The following is a description of a gene set: Human Gene Set: GOBP_POSITIVE_REGULATION_OF_PROSTAGLANDIN_BIOSYNTHETIC_PROCESS species: Homo sapiens Any process that activates or increases the frequency, rate or extent of the chemical reactions and pathways resulting in the formation of prostaglandin., and this is the list of marker genes: PTGS2, AVPR1A, PLAA, IL1B, PLA2G3, CD74, AVP